The following is a description of a gene set: Reactome Pathway: ZBP1(DAI) mediated induction of type I IFNs studied in species Homo sapiens Z-DNA-binding protein-1 (ZBP1), also known as, DNA-dependent activator of IFN-regulatory factors (DAI) was reported to initiate innate immune responses in murine L929 cells upon stimulation by multiple types of exogenously added DNA (Takaoka A et al 2007). Human cytomegalovirus (HCMV) was shown to stimulate ZBP1-mediated induction of IRF3 in human foreskin (DeFilippis VR et al 2010). ZBP1 was also implicated in activation of NF-kappaB pathways in human embryonic kidney HEK293T cells (Kaiser WJ et al 2008, Rebsamen M et al 2009). However, the role and importance ofZBP1 as dsDNA sensor remain controversial, since knocking down ZBP1 expression in other human or murine cell types by siRNA had very little effect on cellular responses to cytosolic DNA, suggesting the presence of alternative pathway (Wang ZC et al 2008, Lippmann J et al 2008). Tissue-specific expression of human ZBP1 also suggests that ZBP1 may function in cell-type specific way (Rothenburg S et al 2002).<br> part of: Cytosolic sensors of pathogen-associated DNA , and this is the list of marker genes: IKBKB, NLRP4, NKIRAS1, NFKB1 (nuclear factor kappa B subunit 1), TICAM1, MYD88, IRF3, TLR3, RIPK3, RIPK1, NFKB2, IKBKG, DTX4, CHUK, ZBP1, RELA, NKIRAS2, DHX9, NFKBIB, NFKBIA, TBK1